Given this list of marker genes Ggh, Tyms, Dhfr, Shmt1, Mthfsl, Aldh1l1, Slc46a1 (NCBI Gene Id 68489), Sardh, Ftcd, Gch1, Aldh1l2, Folr1, Folh1, Qdpr, Pcbd2, Atic, Mthfd1l (NCBI Gene Id 77586), Fpgs (folylpolyglutamyl synthetase), Pcbd1, Gart, Dmgdh, Mthfd2l, Mtrr, Pm20d2, Aasdhppt, Spr, Mthfs, Shmt2, Mtr, Pts, Mthfd1, Mthfr, Mthfd2, here is a description of the gene set: Mouse Gene Set: GOBP_PTERIDINE_CONTAINING_COMPOUND_METABOLIC_PROCESS species: Mus musculus The chemical reactions and pathways involving any compound containing pteridine (pyrazino(2,3-dipyrimidine)), e.g. pteroic acid, xanthopterin and folic acid.